The following is a description of a gene set: The directed movement of transition metal ions into, out of or within a cell, or between cells, by means of some agent such as a transporter or pore. A transition metal is an element whose atom has an incomplete d-subshell of extranuclear electrons, or which gives rise to a cation or cations with an incomplete d-subshell. Transition metals often have more than one valency state. Biologically relevant transition metals include vanadium, manganese, iron, copper, cobalt, nickel, molybdenum and silver. species: Homo sapiens Human Gene Set: GOBP_TRANSITION_METAL_ION_TRANSPORT, and this is the list of marker genes: B2M, STEAP2, SLC30A2, ATP7A, ABCB7, SLC39A10, FTH1 (ferritin heavy chain 1), DNM2, ATP2C2, HEPH (NCBI Gene Id 9977), SLC46A1, SLC39A4 (solute carrier family 39 member 4), SLC30A7, ISCU, ASIC3, SLC39A11, SLC30A4, TFR2, SLC41A2, ABCB6, CLTC (clathrin heavy chain), TMEM165, MT3, CUTC (NCBI Gene Id 51076), LMTK2, ATP2C1, TRPM7, AP3D1, FLVCR2, SLC39A5, FTH1P19, SLC39A2, SLC39A8, TTYH1, SLC30A9, SLC30A8, TF, ATP7B, FTL, SLC39A3, FTMT, MELTF, HPX, SLC30A10, TMEM163, SLC46A3, MCOLN1, STEAP4, ATOX1, SLC40A1, SLC31A1, SLC48A1, SLC39A1, SLC39A6, SLC1A1, SLC22A17, FTHL17, ARHGAP1, FKBP4, COX17, MMGT1, STEAP3, SLC39A9, SLC25A37, SFXN1, TCN2, FXN, TRPC7, CYBRD1, ATP13A1, RAB11B, SLC30A1, SLC39A13, TRPM2, HFE, CBLIF, FLVCR1, MCOLN2, LTF, TFRC, HAMP, SLC30A3, PGRMC2, ABCC5, SLC11A1, HEPHL1, SCARA5, SLC30A6, SLC25A28, SLC31A2, MIR210, SLC39A7, SLC30A5, NECTIN1, REP15, TCN1, SLC11A2, LCN2, IFNG, SLC39A14, TRPM3, SLC39A12